The following is a description of a gene set: The ternary complex factor Net/Elk3 is downregulated in hypoxia and participates in the induction by hypoxia of several genes, including c-fos, vascular endothelial growth factor and egr-1. However, the global role of Net in hypoxia remains to be elucidated. We have identified, in a large-scale analysis of RNA expression using microarrays, more than genes that are regulated by Net in hypoxia. In order to gain insights into the role of Net in hypoxia, we have analysed in parallel the genes regulated by HIF-1alpha, the classical factor involved in the response to hypoxia. We identified about genes that are regulated by HIF-1alpha in hypoxia. Surprisingly, when we compare the genes induced by hypoxia that require either Net or HIF-1alpha, the majority are the same (75%), suggesting that the functions of both factors are closely linked. Interestingly, in hypoxia, Net regulates the expression of several genes known to control HIF-1alpha stability, including PHD2, PHD3 and Siah2, suggesting that Net regulates the stability of HIF-1alpha. We found that inhibition of Net by RNAi leads to decreased HIF-1alpha expression at the protein level in hypoxia. These results indicate that Net participates in the transcriptional response to hypoxia by regulation of HIF-1alpha protein stability. studied in species Mus musculus from publication Gross C, Dubois-Pot H, Wasylyk B (PMID 17704799) Human Gene Set: GROSS_HYPOXIA_VIA_HIF1A_ONLY Genes uniquely up-regulated in SEND cells (skin endothelium) at hypoxia after knockdown of HIF1A by RNAi., and this is the list of marker genes: CCNG2, FGB, SRA1, CITED2, VLDLR, BHLHE40, MAFF, AGL